The following is a description of a gene set: Mouse Gene Set: GOBP_GROWTH_PLATE_CARTILAGE_DEVELOPMENT studied in species Mus musculus The process whose specific outcome is the progression of the cartilage that will provide a scaffold for mineralization of endochondral bones as they elongate or grow., and this is the list of marker genes: Matn1, Nppc, Sox9, Carm1, Dspp, Comp, Cst5, Ift80, Rarb, Thbs1, Cer1, Thbs3, Mmp13, Poc1a, Zmpste24, Tgfbr2, Npr2, Fosl2, Rara, Atf2, Por, Rarg, Col9a1, Col27a1 (NCBI Gene Id 66652), Stc1